The following is a description of a gene set: Human Gene Set: HP_LONG_FINGERS Long fingers The middle finger is more than 2 SD above the mean for newborns 27 to 41 weeks EGA or above the 97th centile for children from birth to 16 years of age AND the five digits retain their normal length proportions relative to each other (i.e., it is not the case that the middle finger is the only lengthened digit), or, Fingers that appear disproportionately long compared to the palm of the hand. species: Homo sapiens, and this is the list of marker genes: PHGDH, TELO2, POLR3H, KMT2A, BRD4, PRIM1, FARSA, BRF1, DSE, KATNB1, MTM1, GNAI1, EBP, AMMECR1, MYLK, LARS1, BCR, PIGN, YRDC, OSGEP, PTCH2, CLCN3, FLNA, TBX4, NAA80, AIP, FIG4, LETM1, KIF7, RETREG1, TBR1, EHMT1, MED12L, RYR1, TGFB3, RUNX2, KDM5C, BCORL1, BGN, COL2A1, EFEMP2, SLC2A10, SKI, AMER1, CLP1, PHIP, EXOSC5, BMP1, DPYSL5, CRELD1, PIGB, SCN9A, GATA4, NUP107, HNRNPH2, TRIO, SUFU, RNU4-2, ADNP, PQBP1, SOX5, TNNT3, COPB1, COL11A1, CCDC88A (NCBI Gene Id 731560), SH2B1, SMC1A, H3-3A, ACTG2, ARVCF, PIEZO2, PRR12, NSDHL, COG7, CPLX1, LAGE3, COL1A2, INPPL1, SMAD3, SMARCAD1, NPR3, IPO8, TCF4, ARX, PRKAR1B, DLG4, CYP26B1, NAA10, CNTN1, CPT2, TFE3, FGFR2, GATAD2B, ZSWIM7, CNOT1, SLC32A1, PEPD, ZMYM2, IARS2, RAB11B, SMAD2, EBF3, ASXL3, SVBP, SMARCE1, ALG12, SLC25A46, HERC1, TRPM3, ODC1, STUB1, HEATR3, GABRA3, GATA2, KMT2E, GJB4, RPL10, TGFB2, PHF8, TUBB, B3GALT6, KMT2C, POR, CDKL5, SPEN, MAPK1, PIGA, ZMIZ1, DPH5, SATB2, WASF1, CNOT3, SETD1B, CBS, PTCH1, MAT2A, BNC1, POLR3A, GP1BB, ZEB2, TCF20, NALCN, NKAP, ASPH, CTBP1, TMCO1, PIGG, MAPRE2, FSHR, PRKG1, PRDM5, PYCR2, SMARCA2, PIGV (phosphatidylinositol glycan anchor biosynthesis class V), DLX5, SLC39A13, DPAGT1, PSMB8, HIVEP2, ZNHIT3, CTCF, TPR, LMNB2, PTRH2 (NCBI Gene Id 51651), FBLN5, RREB1, WNK1, CRKL, TMEM94, ATP2B1, CDC42BPB, YY1, AHDC1, PHF6, MSH4, TGFBR1, FOXE3, MAP1B, KCNE5, RUSC2, HUWE1, NR4A2, SPIDR, MED12, SMS, PLAA, IRX5, TRAPPC9, NSD2, SPTAN1, PAX1, SMAD4, OTUD6B, USP9X, ZFX, NFIX, PSMC3IP, HDAC8, FBN2, MAP3K7, ACTA2, EIF2S3, MYMK, SLC4A10, PLOD1, CHST14 (NCBI Gene Id 89881), RFX7, XYLT2, EED, EFEMP1, TBX1, UPF3B, MTHFS, KDM1A, ASXL1, KDSR, DHX30, CHD4, RECQL, NR5A1, KIFBP, CCNK (NCBI Gene Id 8812), ACSL4, C1R, TWIST1, SPEG, MYOD1 (NCBI Gene Id 4654), FGFR3, EXOC6B (exocyst complex component 6B), SUPT16H, TBCK, NELFA, GJA1, LAS1L, ZDHHC9 (zinc finger DHHC-type palmitoyltransferase 9), PCGF2, NR2F1, H3-3B, ZNF469, TP53RK, SEC24C, NPR2 (natriuretic peptide receptor 2), PAPPA2, FBN1, SPOP, CTSC, JMJD1C, BMP15, PUF60, CHRNG, MAGEL2, NARS1, WLS (Wnt ligand secretion mediator), SLC25A12, B4GALT7, ELN, RNF13 (NCBI Gene Id 11342), SIM1 (NCBI Gene Id 6492), HIRA, COL12A1, KIF1A, DOCK3, ALG14, TGFBR2 (NCBI Gene Id 7048), GNB2, UBE3B, DDX6, HNRNPH1, UNC80, TTN, LOX, ATRX, MAF, GJB3, COL3A1, THSD4, ALG3, MRPS22, VAC14, ADAMTSL1, PHF21A, BMP4, CIC, GPR101, ABL1, PMM2, SCARF2, CRLF1, SNIP1, FBXO11, MFAP5, ECE1, PUM1, ACBD6, SOX6, KANSL1, RPS6KA3, CDC42, HECTD4, SON, HEY2, MYH11, SIN3A, UFD1, GNB1, COL6A2, SLC12A6, VPS13B, DYRK1A, COMT, BIN1, H4C5, AEBP1